Given this list of marker genes LPAR1, CAMSAP3, KAT2A, VPS4B, PIK3R1 (NCBI Gene Id 5295), ARHGEF10, NCKAP1L, STMND1, RHOBTB1, MID1IP1, S1PR1, CDC42EP1, CHMP4B (charged multivesicular body protein 4B), PLXNA3, SKA2, ARFGEF1, BCAS3, CFL1, PDXP (NCBI Gene Id 57041), STMN2, CDK5R2, SMAD3, HAUS3, CARMIL2, WAS, MET, CAV3, PDCD6IP, GMFG, CHMP1B, TAOK2, TTC8, NF2, ODAM, MKKS, MYO3A, SMAD4, PPP2CB, CHMP5, RALA, CDK5R1, PTK2B, SPTA1, WASHC2A, C15orf62, CCL26, TOGARAM2, HCK, RDX (NCBI Gene Id 5962), KANK1, CDC42EP2, MIR20A, SNX9, ABITRAM, BORA, PIK3CA, BIN1, CIB1, MAP2, CCDC15, BAG4, ARHGEF10L, CDC42EP5, TRAF3IP1, SFRP1, PLEK, DAPK3, SPEF1, RND2, SHANK1, WNT4, WASHC5, BMERB1, SSH2, MIR214, CX3CL1, PREX1, ATXN7, ADD1, TAC1, CENPJ, CSF3, CDH5, SYNPO2, COTL1, PFN3, TSC1, MLST8, ARHGEF2, BRK1, ANKRD23, BAIAP2L1, PPFIA1, ROCK1, PHLDB2, TESK1, ARHGAP17, BMP10, APC, STAU2, MAP6D1 (MAP6 domain containing 1), CHMP2A, ADD2, ARHGAP28, SH3BP1, TMEM67, CLIC4, TGFB2, SLC39A12, CYFIP2, PFDN2, ADD3, WASH3P, VIL1, FCHSD2, ASB2, INPP5J, RHOD, MAP1B, IQGAP2, PRKCD, BRCA1, RGCC, SPECC1L, SKA3, OR2A4, NGEF, ARPC5, CDC42EP3, TOGARAM1, NUP62, CAMSAP2, SHANK3, CLN3, CAMSAP1, CAPN10, SPAST, RHOBTB2, GPM6B, KATNBL1, ELN (elastin), EVL, PRKAA2, AKAP13, TRPV4, SYNPO, ARPC2, MAGEL2, GRHL3, CHMP7, PTGER4, ABL1, CAPZA1, CDK2AP2, ALOX15 (NCBI Gene Id 246), RICTOR, MAP9, MECP2, SSH3, CSF1R, DYRK1A, CAPG, KIF18A, NRP1, SDC4, PRKN, DLG1, ROCK2, GMFB, APOA1, TPPP, DMTN, HAUS5, MTSS1, MAPK15, WASF3, WASH6P, MAP1S, CGNL1, BRAF, GNAI1, ACTN2, SSH1, PRKCE (NCBI Gene Id 5581), DNAI3, RND3, PRKAA1, MAPRE1 (NCBI Gene Id 22919), PLK4, PFN2, HAUS6, SPTAN1, AKAP9, SLAIN2, ARHGEF16, GAS2L2, MAPK3, CEP70, NPHS1, CAPN2, DAAM2, NEXN (nexilin F-actin binding protein), CYRIA, RCC1, GIT1, RHPN2P1, SYNPO2L, HAUS2 (HAUS augmin like complex subunit 2), NUMA1, CHMP1A, WASHC3, FLNA, ALMS1, BAIAP2, CDC42, SKA1 (NCBI Gene Id 220134), LIMK1, RHOA, CENATAC, TACSTD2, TRIM36, AMOT, CCR7, TWF2, SLAIN1, KANK4, NME7, CRACD, RGS4, KANK3, SPTB, STIL, RAPGEF3, CKAP5, PLEKHH2, SORBS3, TMOD4, FHOD1, CCL21, WNT3A, PFN1, DLC1, NAV3, INPP5K, NUBP1, CHMP4A, WASHC4, OAZ3, NAA80, PDE4DIP, PRKD1, SEMA5A, EDN1, KIF21A, SCIN, TPM1, DVL2, CORO1A, ABI2, PRUNE1, WASF2, PTK2, HRAS, CDK5RAP2, FKBP4, ARHGEF19, RAC3, FCHSD1, ACTG1, S100A9, CDK10, APC2, HRG, TPX2, CYLD, CARMIL1, DIXDC1, EPHA5, TRIOBP, ARHGEF18, KANK2, LMOD2, ARAP3, VASP, ARF1, SASS6, FSD1, ARHGEF7, FZD10, CD2AP, BST2, MTPN, NEB, PIK3R2, HSPA1A, TMOD1, CEP97, ARFIP1, SIGLEC15 (sialic acid binding Ig like lectin 15), MIR1-1, ATAT1, DYNC1H1, EML2, TRIM27, CCN2, CARMIL3, TRIM54, SPTBN5, STMN4, FER, MIR138-1, TGFB1, DSTN, SVIL, RAC1, HNRNPU, KATNB1, CHMP2B, CORO2B, CCNF, LRP1, JAM3, ARHGAP40, P2RX7, SLC9A1, DVL3, SPTBN1, PLK1, LATS1 (large tumor suppressor kinase 1), WASHC2C, GRB2, TWF1, CLASP2, FGF13, EML3, EPHA3, RNH1, MIR335, HDGFL3, CYRIB, SENP6 (SUMO specific peptidase 6), IQCJ-SCHIP1, CTTN, PROX1, ARAP2, AVIL (NCBI Gene Id 80056), RAE1, RASA1, MYO3B, ARHGEF15, ARL2, BICD2, CLTC (clathrin heavy chain), CHMP4BP1, TACR1, RHPN2 (rhophilin Rho GTPase binding protein 2), ITGB3, ARHGAP44, HSPA1B, CAPN6, NEDD9, RHPN1, SPTBN4, PAFAH1B1, RNF4, ARPC3, BICD1, HAUS8, MAPRE3, PLXNB1, MAP6, NCKAP1, FAM107A, SNCA, ARF6, GAS2L1, CLIP1, CAPZB (NCBI Gene Id 832), MID1, PARP3, PAK3, ARHGEF5, POC1B, FLII, ARHGAP6, CKAP2, S100A10, TRPM2, CAPZA2 (capping actin protein of muscle Z-line subunit alpha 2), NPM1, SPATA4, CD47, GBA2, MAPRE2, RIPOR2, ASAP3 (ArfGAP with SH3 domain, ankyrin repeat and PH domain 3), TTBK2, GSK3A, TMOD3, BBS4, RAC2, F11R, PDGFRB, WASF1, CHMP4C, ECT2, ANKRD53, PPM1F, CEP120, INPPL1, MYLK3, TRIM37, SPTBN2, MAP1A, HCLS1, F2RL1, ARHGAP35, PDGFA, HAX1, FERMT2, ABL2, PAK1, DCTN1, TJP1, DIAPH3, TGFBR1, WDR47, WDR1, BST1, CAPZA3, MAPK1, MYOC, PICK1, AURKB, STMN3, ARAP1, TMSB4Y, PYCARD, ESAM, CDC42EP4, MYADM, GPR65, CYFIP1, CCSAP, PDGFRA, HAUS1, CCDC88A, WASHC1, AP1AR, TENM1, CELSR1, NCK1, SMIM22, SERPINF2, RBM14, MDM1, TMSB4X, TBCD, CLIP3, PEAK3, KIRREL1, CCL24, NAA20, GSN, MIR21, CLASP1, ARHGEF26, ARFIP2, PXN, EPHA1, HAUS4, GPSM2, PHLDB1, MARK2, WHAMM, CFL2, PLEKHG2, EPS8, FSCN1, SLIT2, CXCL12, CCL11, MYCBP2, HAUS7, C9orf72, TMOD2, PPP2CA, CTNNA2, MTOR, TMEFF2, SLC4A2, ARHGAP18, PPM1E, FES, LIMA1, ITGB1BP1, MAPT, RHOF, KAT2B (NCBI Gene Id 8850), RPS3, HIP1R, RHOQ, TACC3, CHMP3, XIRP2, CRK, TAOK1 (NCBI Gene Id 80214), PAK2, RHOG, DIAPH1, TUBB4A, TGFB3, CHMP6, TPR, BAIAP2L2, PKD1, ARPIN, CDKN1B, RND1, LMOD1, HDAC6, PSRC1, SWAP70, PPP1R35 (protein phosphatase 1 regulatory subunit 35), SYDE1, OCLN, EZR, MIR149, STMN1, SPAG5, CORO1B, CIT, FRMD7, CCDC88C, NCK2, GSK3B, CEP295, VILL, EFNA5, DRG1, LIMCH1, LMOD3, ARPC5L, RHOC, BBOF1, S100A8, VANGL2, NES, here is a description of the gene set: species: Homo sapiens Any process that modulates the frequency, rate or extent of the formation, arrangement of constituent parts, or disassembly of cytoskeletal structures. Human Gene Set: GOBP_REGULATION_OF_CYTOSKELETON_ORGANIZATION